The following is a description of a gene set: Any process that stops, prevents or reduces the frequency, rate or extent of protein localization to microtubule. Mouse Gene Set: GOBP_NEGATIVE_REGULATION_OF_PROTEIN_LOCALIZATION_TO_MICROTUBULE studied in species Mus musculus, and this is the list of marker genes: Abhd17b, Map1a, Abhd17c, Abhd17a, Ttbk2